The following is a description of a gene set: studied in species Homo sapiens Synthesis of bile acids and bile salts Human Gene Set: REACTOME_SYNTHESIS_OF_BILE_ACIDS_AND_BILE_SALTS, and this is the list of marker genes: OSBPL7, NCOA1, OSBPL3, SCP2, AMACR (alpha-methylacyl-CoA racemase), SLC27A2, AKR1C2, NCOA2, CYP39A1, SLC27A5, AKR1C3, HSD17B4 (NCBI Gene Id 3295), AKR1D1 (aldo-keto reductase family 1 member D1), OSBP, AKR1C4, AKR1C1, CYP27A1, ACOX2, OSBPL1A, RXRA, OSBPL2, ACOT8, OSBPL6, CH25H, CYP7B1, OSBPL9, NR1H4, CYP46A1, HSD3B7, CYP8B1, BAAT, ABCB11, CYP7A1